Given this list of marker genes KRAS, SOS1, FGF23, FGF8, PIK3CA, FGF20, FGF19, FGF16, FRS3, GRB2, FRS2, FGF2, FGF17, NRAS, FGF6, HRAS, PTPN11, PLCG1, SHC1, KLB, FGF1, FGF9, GAB1, PIK3R1, FGF4, FGF18, FGFR4, here is a description of the gene set: studied in species Homo sapiens Signaling via FGFRs is mediated via direct recruitment of signaling proteins that bind to tyrosine auto-phosphorylation sites on the activated receptor and via closely linked docking proteins that become tyrosine phosphorylated in response to FGF-stimulation and form a complex with additional complement of signaling proteins. <br><br>The activation loop in the catalytic domain of FGFR maintains the PTK domain in an inactive or low activity state. The activation-loop of FGFR1, for instance, contains two tyrosine residues that must be autophosphorylated for maintaining the catalytic domain in an active state. In the autoinhibited configuration, a kinase invariant proline residue at the C-terminal end of the activation loop interferes with substrate binding while allowing access to ATP in the nucleotide binding site.<br>In addition to the catalytic PTK core, the cytoplasmic domain of FGFR contains several regulatory sequences. The juxtamembrane domain of FGFRs is considerably longer than that of other receptor tyrosine kinases. This region contains a highly conserved sequence that serves as a binding site for the phosphotyrosine binding (PTB) domain of FRS2. A variety of signaling proteins are phosphorylated in response to FGF stimulation, including Shc, phospholipase-C gamma and FRS2 leading to stimulation of intracellular signaling pathways that control cell proliferation, cell differentiation, cell migration, cell survival and cell shape. part of: Signaling by FGFR4 Reactome Pathway: Downstream signaling of activated FGFR4